Given this list of marker genes Slitrk1, Slit2, Mapt, Garem2, Mag, Anapc2, Adcy10, Robo1, Llph, Atg16l1, Nrp1, Spag6l, Cdkl3, Cpne9, Slc9a6 (solute carrier family 9 (sodium/hydrogen exchanger), member 6), Nrn1l (neuritin 1-like), Cacng7, Csf1r (NCBI Gene Id 12978), Slc23a2, Pou4f3, Zfyve27, Flrt1, Smurf1, Sh3glb1, Bcan, Lrp1, Mt3, Pou4f2, Fn1, Syt3, Abl1, D130043K22Rik, Myo5b, Stk11, Iqgap1, Hdac6, Sema5a, Bmpr2, Pak1, Barhl2, Sema3g, Plxna3, Jade2, Aurka, Cdh1, Ep300, Tnr, Adnp, Trpv2, Pak6, Ptprs, Bdnf, Tiam1, Eif4g2, Dbn1, Cdkl5, Edn2, Wnt5a, Sema3f, Eif2b2, Slc39a12, Mecp2, Wdr36, Ostn, Mul1, Actr3, Dnm2, Olfm1, Tnn, Prickle1, Syt17 (NCBI Gene Id 20984), Limk1, Cxcl12, Slit1, Dvl1, St8sia2, Rims1, Dscam, Spg11 (NCBI Gene Id 98786), Islr2, Tsc22d4, Cdh4, Map3k13, Pafah1b1, Map2, Ilk (NCBI Gene Id 16202), Usp9x, Mir124a-2, Flrt3, Dip2b, Sema6c, Ccr5, L1cam, Kdm1a, Apoe, Dcx, Syt2, Clasp2, Ttc3, Eif2ak4, Ntrk3, Smo, Sema7a, Lamb2, Arhgap32, S100b, Vegfa, Nrn1 (NCBI Gene Id 68404), Cpne6, Trpc5, Golga4, Sema3a, Trim46, Alcam, Bcl11a, Itsn2, Auts2, Edn3, Wnt3, Sh3gl2, Nedd4l, Ssna1, Rasal1, Mgll, Ulk2, Dclk1, Srf, Spag6, Raph1, Macf1, Wasf1, Reg1, Plxna1, Impact, Nlgn3, Rnf157, Fstl4, Ttl, Ulk1, Disc1, Ryk, Plaa, Shtn1, Edn1, Gsk3b, Itga4 (NCBI Gene Id 16401), Sin3a, Nkx6-1, C9orf72, Itgb1, Rtn4r, Slit3, Hnrnpk (NCBI Gene Id 15387), Wnt3a, Ctnnb1, Ndn, Megf8, Ednra, Rpl4, Rtn4, Prkn, Cdk5, Ifrd1, Emx1, Afdn, Cpne5, Cttn, Rufy3, Fxn, Nrp2, Lhx2, Tmem108, Spag9, Cyfip2 (NCBI Gene Id 76884), Map1b, Syt4, Tnfrsf12a, Cyfip1, Rnf6, Ndel1, Gdi1, Ntn1, Dbnl, Postn, Vcl, Plxna4, Sema6d (NCBI Gene Id 98780), Picalm, Arhgap4, Cpne1, Unc13a, Ngf, Rims2, Twf2, Clstn3, Mir124a-1, Pten, Rab21, Draxin, Prkcz, Syt1, Ddr1, Cxcr4, Sema4f, Sema5b, here is a description of the gene set: studied in species Mus musculus Long distance growth of a single neuron projection involved in cellular development. A neuron projection is a prolongation or process extending from a nerve cell, e.g. an axon or dendrite. Mouse Gene Set: GOBP_NEURON_PROJECTION_EXTENSION